The following is a description of a gene set: studied in species Homo sapiens from publication Zhu Y, van Essen D, Saccani S (PMID 22633489) Human Gene Set: GSE32255_UNSTIM_VS_4H_LPS_STIM_DC_DN In dendritic cells, expression of the H3K9me3 demethylase JmjD2d is upregulated by LPS stimulation. To identify genes whose induction by LPS depends on JmjD2d activity, we performed a microarray analysis of wild-type and JmjD2d-knockdown dendritic cells, before and after stimulation with LPS. Genes down-regulated in dendritic cells: unstimulated versus LPS., and this is the list of marker genes: RAB5A, EIF1AD, DDR1, TMEM134, LFNG, TNFRSF13B, ACO2, MAGEB17, PLCD1 (phospholipase C delta 1), TXLNB, AIP, JAZF1, MT-ND2, AK2, MT1A, PLXND1, MANSC1, PPP3CC, MALT1, GPLD1, HERPUD1, TRIML2 (tripartite motif family like 2), SAAL1, CD38, CPA3, TBC1D23, KIF7, HEXB, BATF, MTCH1, LGMN, ACP3, RNF212, TMED2, ABLIM1, EVA1B, MYADM, PIM2, TMED7, SCAMP2, IRF5, S100A10, S100A11, GPX1, RORC, TIGIT, TMCO5A (transmembrane and coiled-coil domains 5A), ANGPTL2, TNFAIP8L2, CCDC32, CPNE4, NUCB1 (NCBI Gene Id 4924), AHR (NCBI Gene Id 196), GLRX, IFI30, PRKAA2, GRAP, CD22, ARNT2, MGP, CORO2B, CANX, GTPBP10, PTTG1IP (PTTG1 interacting protein), ASB6, CKB, FARS2, MRI1, STXBP2, SMARCE1, SERTAD1, ATP1B3 (NCBI Gene Id 483), STK17B, RFK, CNKSR2 (connector enhancer of kinase suppressor of Ras 2), B4GALNT4 (NCBI Gene Id 338707), MPP2, MAVS, SCPEP1, DKKL1, TAGAP, ECH1, SNORD14E, NAV2, PARVG, CALM1, STX6, TMSB4X, SASH3, FLACC1, CDK2AP1, PPT1, PTPN7, ARMC7, RAPGEFL1, IRF3, ACADS, RRP1B, HTATSF1, IL13RA1, PIGS, MCC (NCBI Gene Id 4163), PUF60, DR1, CCND3, IKBIP, ANKRD34C, MOB3A, NFYC, LRRN4, COBLL1, NUDC, UCK1, ST6GALNAC1, FSTL4, ORAI1, PTPN18, NDUFAF3, CCNJL, RPS27, AMDHD2, FAM114A1, H2AC4, ARL5A, OSBPL2, KIF6, TOMM34, MYL6B, RUNDC3A, ATCAY, DNASE1L3, PAICS, RBM45, METTL17, PTPRZ1, TST, CCNDBP1, NIPSNAP3B, BRD9, SMPDL3A, GPR61, ATG12, PRELID2, PBX3, HES2, TACO1, ICOS, S100A6, GDPD1, RPL28, SPINT2, FAH, BAG3, SH3RF2